Given this list of marker genes TRMT13, UCN2, YARS1, VEGFA, SMG5, GIGYF1, PSCA, DCTN1, FGF6, PTCHD1, ANKS1B, HOXA9, CREB3L2, BRME1, ERF, LMO1, EPHB1, SEMA3A, FBXW4, CTDSP1, KIF1C, NRGN (neurogranin), TTC9C (NCBI Gene Id 283237), TAOK2, POGZ, ABL1, RGS8, ZNF689, RTN2, PRKAG1, ASB7, WDR20, MAP3K11, ACOT8, ZBTB17, RIN1, MIA2, ESRRG (NCBI Gene Id 2104), PKP3, ADD3, CDH17, SMARCA5, SERPINF2, PURA, PMEL, PPP1R9B, OTX1, EML3, NKX2-1, PAK1, AKTIP, HR, RAD23B, KCNB1, TMEM79, TSNAXIP1, PHKG2, INCA1, PPM1N, POFUT1, PPTC7, FSCN3, DNAJC27, CYC1, CLUH, VWA7, GGN, TMEM125, LINS1, WNT4, TRIB1, BIN2, STIP1, ZSWIM3, MAN2B1, ROGDI, BAHD1, NEUROG1, RTN4, DLG2, CRYBG2, MAFB, PLAGL2, AHCYL2, ATOSB, TNXB, CACNA1S, CBX6, MNT, KPNB1, HMGN2, PRX, LEFTY2, TRPV6, SUPT16H, CFAP69, NRG2, PDGFB, ZNF41, NXPH3, SLITRK5, SCAMP3, NUFIP2, SASS6, UBE2K, CYP2W1, ATP5MC2, ROM1, LAMA5, DHH, ADAP2, PHF12, DNAJC7, CDK5R2, KRTAP6-3 (keratin associated protein 6-3), RFX1, CORO6, HOXA5, CHD2, LOXL4, ARHGAP26, OSM, HRH3, LCOR, CHMP2B, NEUROD2, NLGN3, DDX17, MSI1, ARF6, PGF, NKIRAS2, EPN1, here is a description of the gene set: Human Gene Set: PPARA_02 studied in species Homo sapiens Genes having at least one occurrence of the motif NNRGGTCATWGGGGTSANG in the regions spanning 4 kb centered on their transcription starting sites. This matches the PPARA transcription factor binding site V$PPARA_02 (v7.4 TRANSFAC).